Given this list of marker genes Ndufb2, B2m, H2-D1, Foxn3, Mplkip, H2-K1, Tasp1, Ppp3cc, Inpp4b, Cnp, Gmcl1, Nucks1 (nuclear casein kinase and cyclin-dependent kinase substrate 1), Il4ra, H2-DMa, Hipk2, here is a description of the gene set: Cytokines mediate cell-cell communication in the immune system and represent important therapeutic targets. A myriad of studies have highlighted their central role in immune function, yet we lack a global view of the cellular responses of each immune cell type to each cytokine. To address this gap, the authors created the Immune Dictionary, a compendium of single-cell transcriptomic profiles of more than 17 immune cell types in response to each of 86 cytokines (>1,400 cytokine-cell type combinations) in mouse lymph nodes in vivo. A cytokine-centric view of the dictionary revealed that most cytokines induce highly cell-type-specific responses. For example, the inflammatory cytokine interleukin-1β induces distinct gene programmes in almost every cell type. A cell-type-centric view of the dictionary identified more than 66 cytokine-driven cellular polarization states across immune cell types, including previously uncharacterized states such as an interleukin-18-induced polyfunctional natural killer cell state. Genes positively differentially expressed in cell type: Treg upon treatment with cytokine: IL-4 in mouse lymph nodes in vivo. Mouse Gene Set: CUI_TREG_IL4_RESPONSE_UP from publication Cui A, Huang T, Li S, Ma A, Pérez JL, Sander C, Keskin DB, Wu CJ, Fraenkel E, Hacohen N (PMID 38057668) species: Mus musculus